Given this list of marker genes Ccnb1, Ube2d1, Ube2s, Anapc7, Ube2e1, Ube2c, Cdc23, Plk1, Cdc26, Anapc15, Anapc10, Anapc2, Cdk1, here is a description of the gene set: part of: Activation of APC/C and APC/C:Cdc20 mediated degradation of mitotic proteins studied in species Mus musculus electronically inferred by orthology from the curated human pathway Reactome Pathway: Phosphorylation of the APC/C This event has been computationally inferred from an event that has been demonstrated in another species.<p>The inference is based on the homology mapping from PANTHER. Briefly, reactions for which all involved PhysicalEntities (in input, output and catalyst) have a mapped orthologue/paralogue (for complexes at least 75% of components must have a mapping) are inferred to the other species.